Given this list of marker genes E2F8, ARID3A, CDKN1B, CDK2, CCNE2, CCNA1, ZNF385A, CCNE1, E2F1, TP53, PCBP4, CCNA2, CDKN1A, E2F7, here is a description of the gene set: Human Gene Set: REACTOME_TP53_REGULATES_TRANSCRIPTION_OF_GENES_INVOLVED_IN_G1_CELL_CYCLE_ARREST species: Homo sapiens TP53 Regulates Transcription of Genes Involved in G1 Cell Cycle Arrest